The following is a description of a gene set: from publication Chen Y, Wang X (PMID 31504780) studied in species Homo sapiens Human Gene Set: MIR3651 Genes predicted to be targets of miRBase v22 microRNA hsa-miR-3651 in miRDB v6.0 with MirTarget v4 prediction scores > 80 (high confidence targets)., and this is the list of marker genes: FBXW8, CCDC144A, ITSN2, HEY1, ANKRD18A, PHTF2, GABRG2, PMAIP1 (phorbol-12-myristate-13-acetate-induced protein 1), RFX4, IP6K3 (NCBI Gene Id 117283), ATP6AP2, USP13, TMPRSS12, CACNA1B, PTPRQ, ABITRAM, FRMD3, TCEA1, SEC63, USP32